The following is a description of a gene set: Human Gene Set: GOBP_POSITIVE_REGULATION_OF_MRNA_3_END_PROCESSING species: Homo sapiens Any process that activates or increases the frequency, rate or extent of mRNA 3'-end processing., and this is the list of marker genes: NCBP1, NCBP2, CDC73, CCNB1, DHX36